Given this list of marker genes GNG3, ADCY4, GNG7, GABRR3, GABRB1, GABRR1, ADCY3, GNGT2, GNG11, GNG12, GNAI2, KCNJ2 (NCBI Gene Id 3759), GNG13, GABRQ, GNB4, GNAT3, KCNJ10, GNB5, KCNJ3, GABRA2, GNG2, KCNJ5, GABRA3, GABRR2, GABRG2, ADCY2, ARHGEF9, GNG5, GABRG3, ADCY8, KCNJ6, GNG8, ADCY6, GNAI3, NPTN, GABRB3, KCNJ15, ADCY1, GNB3, GNAL, KCNJ12, GNGT1, GABBR2, ADCY9, GNAI1, GABRA5, KCNJ16, ADCY7 (NCBI Gene Id 113), GABRA4, GNB2, GNB1, GNG10, GABBR1, GABRA6, KCNJ9, GABRA1, KCNJ4, ADCY5, GNG4, GABRB2, here is a description of the gene set: Human Gene Set: REACTOME_GABA_RECEPTOR_ACTIVATION studied in species Homo sapiens GABA receptor activation